The following is a description of a gene set: The process of targeting specific proteins to particular regions of the cell, typically membrane-bounded subcellular organelles. Usually requires an organelle specific protein sequence motif. Human Gene Set: GOBP_PROTEIN_TARGETING studied in species Homo sapiens, and this is the list of marker genes: AP3M1, TOMM40L, MTCH1, HPCA, VPS53, ITGB2 (integrin subunit beta 2), ZFAND6, MFF (mitochondrial fission factor), LRRK2, VPS13D, NRARP, PEX12, BAP1, ZDHHC7, PIK3R4, GET1, VPS37C, CACNG2, ZFAND2B, PMPCA, CHCHD4, GOLGA7B (golgin A7 family member B), TIMM17A, ATG3, TIMM50, TCAF2, SPCS2, ABLIM3, NPEPPS, SSR1, TIMM21, PDZK1, ICMT, SEC61A2, AKAP6, ZDHHC4, TRAK2, GDI1, ANK3, UBL5, AP4M1, CLU, VPS13C (NCBI Gene Id 57581), TOMM70, ZDHHC19, HOMER3, BID, HSPA1L, SORT1, PEX19, TIMM9, VPS52, FZD5, ZDHHC11, ZDHHC3, TIMM23B, RABGEF1, PAK1, PITRM1, RAB7A, SIRT4, ZDHHC12, GET4, SQSTM1, ZDHHC11B, TRAK1, MIEF1, NACAD, HSPD1, ENSG00000283175, TIMM10, RTP3, WASH3P, ZDHHC14, GNPTG, TOMM34, RHOD, RTP4, HAX1, AQP11, TOMM22, RN7SL3, SYNJ2BP, DNLZ, STXBP4, SRP19, GRPEL1, UBL4A, LMAN1, CACNG3, ANKRD10, BAG3, SIAH3, VPS13A, ERBB2, RTP1, MGARP, FYN, TIMM29, SNAP25-AS1, PINK1, HSPA8, MTX2, PAN3, AIP, ARL6IP1, GFER, ZDHHC18, ADORA1, ZDHHC24, TOMM5, ATP5IF1, PIK3C3, TIMM22, AP4S1, PRKCI, SRP72, ZDHHC2, LAMP2, ITGAM, IRGM, GNPTAB, TRAM2, CDK5R1, TRAM1, ARIH2, HTRA2, SORL1, TOMM40, HPS4, CHMP4A, RN7SL2, VPS41, MAN1A1, HAP1, ROMO1, MTCH2, ZDHHC22, SIL1, SPCS3, C11orf65, GRPEL2, GLP1R, NACA2, SREBF2, MICALL1, KCNE1, PARL, ERBIN, YWHAZ, SDCBP, PIKFYVE, GGA3, LARGE1, TIMM10B, ZFYVE16, YWHAQ, MIPEP, ANKRD6, SRP14, YWHAE, HSPA5, ZDHHC9, TIMM44, PRKN, GOLPH3, HERPUD1, PAM16, GOLPH3L, SEC63, MFN2, MIEF2, AIFM1, ZDHHC15, USP17L2, GDAP1, SRP9, MYO1C, CDKN2A, SEC61A1, GOLGA7, DNAJC19, FUT10 (fucosyltransferase 10), IMMP2L, SLC51B, HRAS, SREBF1, SAMM50 (NCBI Gene Id 25813), SMURF1 (NCBI Gene Id 730332), RTP2, KCNQ3, VPS4A, LEPROT, LTBP2, CSNK2A2, YIF1B, SYNGR1, RASSF9, OS9, TRAM1L1, PEX5, MTERF4, HUWE1, VPS11, YWHAB, CWH43, NEDD4, SSR2, AP1S3, SAE1, BAG4, VPS37D, SNX16, VPS51, NAGPA, PIN1, RN7SL1, SH3GLB1, SCARB2, SGTA, RNF31, NDP, ZDHHC23, FBXO7, KIF13B, AP1M2, ZDHHC20, SSR3 (NCBI Gene Id 6747), SEC61B, TIMM13, TCAF1, SRPRB, VPS54, TAOK2 (TAO kinase 2), EDEM1, YWHAG, NCOA4, SEC61G, STOM, CHM, TOMM7, BAG6, NACA4P, RPL11, RAB3IP, PEX7, UBE2L3, TOMM20L, KCNB1, RAC2, ANKRD13C, AP4E1, TSPO, TIMM8B, CEMIP, LONP2, GJD2-DT, ZDHHC1, ZDHHC21, PEX6, HACL1, NLGN1, TTC9-DT, NDUFA13, GCC2, RHOU, PMPCB, CHMP4B, MTX1, PRNP, SLC1A1, PML, KATNB1 (katanin regulatory subunit B1), MON1A, DNAJC15, VPS8, NACA, TIMM17B, TOMM6, CHP1, GBP5, BNIP3L, DMTN, TIMM8A, SGTB, ZFAND2A, AP4B1, PEX16, ATG14, USP36, ARL6, ZDHHC6, IMMP1L, INPP5K, GSK3A (NCBI Gene Id 2931), MON1B, ADCY10 (NCBI Gene Id 82259), CIB1 (calcium and integrin binding 1), NCF1, MTCL1, SRPRA, SRP68, UBL4B, M6PR, TRMT10B, C2CD5, TIMM23, FBXW7, CDK5, RTP5 (NCBI Gene Id 285093), AKT2, AP3D1, HSP90AA1 (heat shock protein 90 alpha family class A member 1), BCAP31, PEX1, BECN1, ATG13, SPCS1, GABARAP, VPS37B, PRKAA1, BLOC1S6, SRP54, UBE2D3, LAPTM5, GIPC1, HGS, SEC62, TOMM20, VPS37A, AGK, CDC37, ITGB1BP1, FIS1, UBE2J2, PARD3, MICALL2, HSPA4, AP3B1, BHLHE40-AS1